Given this list of marker genes METTL21C, MIR143, GNB2, SLC26A6, MIR24-1, GRM6, TNF, CALHM1, KCNJ5, KCNC2, OAZ3, TCAF2, ABCC9, MIR873, PSEN1, FFAR4, FLNA, FXYD4, AFG3L2, KCNQ1, BRAF, IRS2, SELENON (NCBI Gene Id 7800), PIK3R1, VMP1, ASPSCR1, AHNAK, LRRC52, GSTM2, CNIH3, F2R, NTSR1, CAV1, CLTRN, SESTD1, KCNJ8, LRRC26, XCL1, ADIPOQ, CASQ2, ATG5, OAZ2, TRPC6, G6PD, TMSB4X, RSC1A1, PRNP, PSEN2, OCLN, OSR1, CACNG8, SCN1B, CACNG4, AKT1, KCNIP3, CAV3, NPPA, MIR200C, CEMIP, GRIN2A, INSR, MS4A1, GPR35, KCNJ1, IL1B, SNCA, BAK1, FXYD1, NR4A3, DAPK1, TMC1, CALM3, UBQLN1, CFTR, ABL1, MIR451A, PML, KCNJ2, ATP2A1, EPO, APP (amyloid beta precursor protein), OPN3, ARL6IP5, CHP1, MIR107, SLC43A1, TERT, F2RL3, AKAP7, KCNIP4, NOS1AP, NPSR1, PPP3R2, RGS9, PER2, TMEM38B, STAC3, ACTN4, CRH, KCNJ3, EDNRA, KCNAB1, GRB10, AZIN2, JPH1, KCNJ6, CX3CL1, PDE4B, CA2, OXSR1, KCNS3, GRIN2C, SIRT6, KCNE2, CNIH2, OPRK1, NOS1, GALR2, ATP2B4 (NCBI Gene Id 54594), FXYD2 (NCBI Gene Id 486), RNASEL, CD19, KCNS2, CRHR1, SNTA1, FXYD6P3, MCUB, PIM1, CACNG7 (NCBI Gene Id 59284), P2RX7, DIAPH1, MIR29B1, PHB2, PPP3CA, AMIGO1, KCNN2, HTT, LYN, YWHAE, RGS2, MIR208B, ATPSCKMT, GRIN2D, MIR93, CD63, SLC30A1, PEA15, MIR495, ITLN1, CLTCL1, CAB39, KCNJ16 (potassium inwardly rectifying channel subfamily J member 16), ACE2, GRP, ATP1B2, COX17, PPP3R1 (protein phosphatase 3 regulatory subunit B, alpha, NCBI Gene Id 5534), KCNE5, LRRC55, P2RX1, RGS4, CXCR3, MIR34B (microRNA 34b), TMBIM6, PTPN11, PPP3CB, MIR210, KLF15, TRDN, SLC17A8, SLC26A5, CACNA1D, EDN3, ATP1B1, P2RY6, YES1, FXYD6, IFNG, CRBN, MIR448, APPL1, KCNG4, PTPRM, DRD1, STAC, CTSS, MMP9, CLDN3, WNK4, AZIN1 (NCBI Gene Id 51582), PTK2B, INS, FKBP1B, TLR9, STXBP4, PPP3CC, NEDD4, GH1, KCNIP2, IGF1, SRI, KCNE1, AKT2, FKBP1A, GRIN1, EDN1, STIM1, CACNG5, POU4F2, GAL (NCBI Gene Id 51083), PRKCE, KCNJ14, CALM1, FXYD3, MINK1, CAPN3, CREBL2, KCNS1, PLA2G1B, PID1, CTTNBP2NL, KCNJ4 (potassium inwardly rectifying channel subfamily J member 4), KEL, LIME1, CACNB4, MIR326, KCNG3, ANK3, ASPH, NGF, HAMP, ACTN2, JPH4, MIR133A1, BCL2, STRIT1, STOM, LACRT, IRS1 (NCBI Gene Id 3667), ANK2, UTRN, MIR185, CALM2, WNK3, FGF19, KCNAB3 (potassium voltage-gated channel subfamily A regulatory beta subunit 3, NCBI Gene Id 9196), CACNG1, DLG1, PRKCB, PRKD1, CORO1A, C2CD5, STK39, P2RX4, NIPSNAP2, SORBS1, ITGB1, ADCYAP1R1, FXYD5, ZDHHC7, FYN, SLC7A5, ANO6, CXCL10, CLIC2, JPH3, MIR9-1, CACNB3, ENPP1, CASQ1, CACNG2, CACNA1C, RTN2, CHD7 (chromodomain helicase DNA binding protein 7), REM1, PDPK1, BPIFA1, KCNG1, HRC, PLN, C1QTNF12, SLC34A1, MIR192, CACNA2D1, ERFE, RYR2, HAP1 (NCBI Gene Id 9001), CERS1, BIN1, YWHAQ, KCNN4, GNB5, VAMP2, MIR129-1, GOPC, MIR212, TRIB3, DPP10, KCNK16, NEDD4L, NFE2L2, BDKRB1, PLCG1, TMEM38A, STXBP3, MIR30D, SLC1A2, AHCYL1, INPP5K, FMR1, MIR328, COMMD1, ATP4A, APLNR, TRPC1, ACSL5, OSBPL8, LCN2, ARPP19, SLN, MIR21, TOR2A, HPCA, ITGB3, MIR208A, HK2, TCIRG1, AKAP5, PRRT1, AGT, CBARP, UBASH3B, ACSL1, TGFB1, STIM2, CALCA, RANGRF, KCNJ13, CTNND1, TMC2, OSTN, KCNRG, ARL6IP1, TCAF1, KCNJ10, CACNB2, CAMK2D, GPER1, GRIA1, P2RX2, SLMAP, CXCL9, WNK2, TRPC3 (transient receptor potential cation channel subfamily C member 3), SPG7, MIR1-1, SPHK2, AKAP6, ATP1A2, KCNC1, MIR186, APPL2, PTPN3, MIR34A, SLC8A1, SEPTIN2, CACNA1F, CLIP3, MEF2A, WWP2 (WW domain containing E3 ubiquitin protein ligase 2), KCNAB2, CACNG6, LEP, CYBA, WNK1, KCNE3, SCN5A, UCP2, FGF13, CRACR2A, DPP6, STAC2, P2RX3, MIR508, KCNJ11, IL13, MIR223, PDE4D, SCN10A, FXYD7, MIR499A, ATP1B3, DMD, C3, SLC25A27, F2, PPIF, ASIC2, VDAC1 (voltage dependent anion channel 1), BAX, PIK3CG, FGF12, PTPN6, UBR3, GSK3A, DHRS7C, OAZ1, ISCU, FHL1, FABP5, CRHBP (NCBI Gene Id 1393), GRIN2B, KCNJ12, CACNB1, SLC31A2, FGF21, KCNJ18, PTH, THY1, SUMO1, CAPN10, STIMATE, RHOQ, PRKCI, MIR133B, HEPH, GPC3, PCSK9, PRKAG2, KCNJ15, RAP1A, JPH2, P2RX5, SELENOS, CACNG3, MIR103A1, CD4, OPRM1, KCNJ9, LRRC38, TESC, CXCL11, KCNIP1, PRKACA, SLC43A2, TSPAN13, KCNH2, SHISA7, GSTO1, MIR26A1, MAPK14, THBS1 (NCBI Gene Id 7057), here is a description of the gene set: Human Gene Set: GOBP_REGULATION_OF_TRANSMEMBRANE_TRANSPORT Any process that modulates the frequency, rate or extent of the directed movement of a solute from one side of a membrane to the other. studied in species Homo sapiens